The following is a description of a gene set: from publication Cipolletta D, Feuerer M, Li A, Kamei N, Lee J, Shoelson SE, Benoist C, Mathis D (PMID 22722857) species: Homo sapiens Genes up-regulated in CD4 T cells over-expressing FOXP3 and PPARg1 isoform of PPARG: untreated versus GW1929. Human Gene Set: GSE37534_UNTREATED_VS_GW1929_TREATED_CD4_TCELL_PPARG1_AND_FOXP3_TRASDUCED_UP Pioglitazone treatment of CD4+FoxP3- T cells transduced with Pparg and Foxp3 up-regulated a set of genes whose products have been implicated in lipid metabolism pathways. To verify the specificity of this treatment, we performed microarray analysis on Foxp3+Pparg1-transduced CD4+FoxP3- T cells after treatment with other PPARg agonists such as Rosiglitazone (TZD) and GW1929 (non-TZD)., and this is the list of marker genes: RING1, CEBPG, MOCOS (NCBI Gene Id 55034), GMDS, DNAJC28, FAM163A, LYL1, SLCO2A1, ERCC1, SPATS2L, FZD4, HK2, PIGH, BST2, TRANK1, SURF1, S100P, BCL2L13, KANK3, PDZD2, HSPBP1, ZCCHC2, KAT8, IFITM1, SHFL, HLA-B, CCDC28A, AARS1, MEF2C, CSF2, MBD2, DUSP3, EHD4, COX7A1, ABCA6, PLEKHA4, MIA2, RGL1, SIRT4 (sirtuin 4), EBAG9, SLC37A4, AURKAIP1, AMFR, IFRD2, GDI2 (NCBI Gene Id 2665), PHF11, DNAL4, TDRD7, FBXL7, GMPR, TENT5A, SCO2, TIMM9, PLAGL1, CRTAC1, TRIM38, PGAM1, OMG, AKT3, PCF11, GYG1 (NCBI Gene Id 2992), IQCB1, FRAS1, EIF1, GLUL, SLC22A5, HERC5, BCCIP, GTF2B, CASP1, BASP1, RAB3IL1, ZNF574, SCN8A, SHB, TTC39A, SLFN12, FYN, SLCO4A1, PLD1, PLPPR1, KCNJ12, HOXB2, RASGRP3, EIF2AK2, KBTBD2, PCDH12, CXCL1, UXS1, TNFRSF11A, ZNF274, RAB32, HACD1, CSNK1D (casein kinase 1 delta), CRBN, SENP3, GLB1L2, DAPK1, ELF1, WASHC4, HIF1A, UAP1, SRR, LTB, CYP2J2, STBD1, PHACTR2, LGALS8, ELF4, IFI6, SPTLC2, MID1IP1, KCNMB1, GPRC5A, DHX58, ZFYVE26, FMR1, STX18, SURF2, PRKD2, NR3C2, PIGC, PROX1, SETX, TYMP, TRIM5, SOCS2, C6orf62, BFSP1, LMO2, USP25, TMEM50A, SAP130, RAB9A, MRPS31, BUD31, SEMA3C (NCBI Gene Id 222200), TNFSF18, DDX60, RAMP2, NFKBIA, YEATS2, PPP1R11, HIVEP1, CREBL2, CRYBG1, LHX6, CSRP1 (cysteine and glycine rich protein 1), HAX1, ZFPM2, RIN2, TSPAN5, EML2, TREX1, SERPINB1, HBEGF (NCBI Gene Id 1839), LGALS9, HLA-C, ETV7, MEPCE, IFI27, COMT, TRIM26, ZNF277, AP3M2, RPS4Y1 (ribosomal protein S4 Y-linked 1), GTPBP2, KPTN, DMAC2L, STX12, URM1, VEGFA, BAG1, NT5E, IL6, IFIT2, CNP, VEZF1 (vascular endothelial zinc finger 1), OGFR, NFKBIE, PALS2 (protein associated with LIN7 2, MAGUK p55 family member), EIF3K, RHOD, RBCK1, SLC1A4, RHBDF2, ARHGAP10, LY6E, TNFAIP3, IL13RA2, HOMER1, ZNF107, CST2 (NCBI Gene Id 1470, cystatin SA), MSX1, ATP10A, RAB3GAP1, IFRD1, SLC16A4, MYD88